Given this list of marker genes Wnt11, Bmpr1a, Wnt3a, Foxc1, Smad2, Lef1, Nckap1, Smad3, Foxc2, Htt, Exoc4, Hnf1a, Wnt5a, here is a description of the gene set: studied in species Mus musculus The process in which the anatomical structures of the paraxial mesoderm are generated and organized. Mouse Gene Set: GOBP_PARAXIAL_MESODERM_MORPHOGENESIS